The following is a description of a gene set: species: Mus musculus from publication Chen Y, Wang X (PMID 31504780) Mouse Gene Set: MIR_329_5P Genes predicted to be targets of miRBase v22 microRNA mmu_miR_329_5p in miRDB v6.0 with MirTarget v4 prediction scores > 80 (high confidence targets)., and this is the list of marker genes: Lrrc27, Sc5d, Zfp14 (NCBI Gene Id 243906), Msl2, Surf4, Adgrb3, E030030I06Rik, Asb7, Irag1, Acbd5, Fstl5, Vti1a, Cdca4, Lce3f, Smarce1, Nup205, Mthfd1l, Btbd3, Bax (BCL2-associated X protein), Cr2, Dcaf7, Prep (NCBI Gene Id 28116), Mapk8, Ptpn11, Ascc3, Garin1a, Fam161b, Lta, Rbm27, Tsfm, Naaladl2, Wdr11, Zfp955a (NCBI Gene Id 77652), Nkain2, Phyhipl, Bnip1, Tead1, Serf2, Xrn1, Lypd6, Grk2, Trib1, Abca1, 1700029F12Rik, Arl15, Klhl29 (kelch-like 29), Yy2, Mrps18b, Nox4, Ccz1, Hnrnpdl, Slmap, Usp28, Lonrf1, Ssh2, Itga9, Memo1, 5730507C01Rik, Slc36a4, Syt11, Arb2a, Psd3, Dcbld1, Slc12a1, Kcns3 (potassium voltage-gated channel, delayed-rectifier, subfamily S, member 3), Cdc42bpg, Nfkb2, Hivep1, Fiz1, Mtx2, Arhgef26, Zfp503, Klf9, Eif5a2, Fkbp1a, Arhgef10l, Emc2, Tcte2, Rbpms2 (RNA binding protein with multiple splicing 2), Tm4sf19, Gyg1, Eml1, Vwde, Adprh, Pcgf3, Herc3, Wdr33, Pkp2, Smad5, Ahrr, Cst6, Adam19, Bod1